Given this list of marker genes TRIOBP, MED4, GALNT11, KCNJ14, ZNF823, NFIA (NCBI Gene Id 4774), MSH5, TBR1, FBXO40, TMEM87A, EGLN3, CCDC91, ZNF512, ZNF45, GIPC3, NMT2, FGF7, NUDT4, TXNRD2, PLGLB2, PPP4R3B, HIPK1, COX20, LCP1, TRIM10, CNTLN, SEMA6A, PRRC1, BCL2L2, NRCAM, PTGES3L, SAV1, RB1CC1, EWSR1, FAM174B, FLT3, TFRC (NCBI Gene Id 7037), ECHDC1, SCNN1B, ZCCHC10, LPGAT1, LILRA1, HMGB3 (high mobility group box 3), NCEH1, BEND4, PRRC2C, NCOA2, C6orf136, HOXB9, ZSWIM6, PLGLB1, SIKE1, PTPN21, TMEM65, HMGN1, LSM8, CHORDC1, USP8, TMEM170B, CREBRF, ELOVL6, DCAF10, RELL1, ADGRB3, KCNIP2, GHSR, RP1, JPH4, KLF15, SS18, OSBPL6, CLK4, ARL2BP, DNM3, ACSM3, G3BP1, SFT2D3, DLL3, RBM27, HYKK, AMZ2 (archaelysin family metallopeptidase 2), LHFPL5, SLC25A33, AJUBA, FLI1, CNNM3, here is a description of the gene set: Human Gene Set: MIR518E_5P_MIR519A_5P_MIR519B_5P_MIR519C_5P_MIR522_5P_MIR523_5P Genes predicted to be targets of miRBase v22 microRNA hsa-miR-518e-5p, hsa-miR-519a-5p, hsa-miR-519b-5p, hsa-miR-519c-5p, hsa-miR-522-5p, hsa-miR-523-5p in miRDB v6.0 with MirTarget v4 prediction scores > 80 (high confidence targets). species: Homo sapiens from publication Chen Y, Wang X (PMID 31504780)